Given this list of marker genes PAQR8, SPAG9, GPR21, ATP5F1A, SNX27, SLC9A9, SCRT2, TFPT, BTBD3, ITGA1, ADO, SLC38A9, SLC25A37, ERC1, APBA1, RAB2A, JAM3, RRM1, SOSTDC1, KCND2, PELO, SESN3, GRID2, ARFGEF1, TMEM245, C19orf44, KMT2D, PRSS35, STAG1, POLK, PLS3 (plastin 3), NTF3, RIMS1, GABRA3, RBMXL2, DPYSL3, RPL7, CBLN4, TMOD3, PRUNE2, BMP4, RCN3, AGA, NOX3, RASSF2, APP, RPS6KA3, BICD1, MOSPD1, SOBP, NKX2-2, PTPRK, LUC7L, GRWD1, OSBPL9, ING3, BBX (NCBI Gene Id 56987), BCKDK, FUT11, BCL11B, TLL2, CCL24, KLHL20, TSSK4, KLF5, LEF1, LGI1, EPS15, CREB5, FEN1, CRYZL1, MRPL50, JARID2, PANK3, GAS7, CBX7, MAGI1, SMCR8, ALKBH4, TBC1D22A, DAB1, NCALD, ATL3, RERE, RSKR, HSCB, CXXC5, GSX1, SAT1, RAB30, ATP5PO (NCBI Gene Id 539), ATP1B2 (ATPase Na+/K+ transporting subunit beta 2), SLC24A3, HHIP, ARID1B, NR5A2, TAF5L, TP63, PCDH7, PRICKLE2, DLG3, MSX2, KCNA1 (NCBI Gene Id 729214), MED12, HOXA5, DELE1, PIK3R1, SMARCA2 (NCBI Gene Id 95083), MBNL1, SMAD5, ZNF436-AS1, MIR17HG, TMEM150A, MVB12A (multivesicular body subunit 12A), PAX6, GHR, NRAS, CSMD3, WNT10A, KDM6A, ZNF32, OSCAR, CERT1, KCNQ4, TSHZ3, ECT2, IPO7, FEZF2, INVS, DAAM2, EDIL3, SUCO, PRPF31, RPL31, ZEB1, TOP3A, FOXP3, ACP6, TMEM104, INO80D (NCBI Gene Id 54891), ZBTB26, ZNF274, HAUS1, HOXD10, RFC1, ANGEL1, SREK1, ZNF691, TMTC2, TMEM35A, CEP97, SYNCRIP, UBE2V1, MOAP1, SH3D21, HOXA11, ASIC1, ESPL1 (extra spindle pole bodies like 1, separase), LHX1, SPEF1, ZNF521, RDH10, FOXD3, CALR3, MSL3, CBFB, DMD (dystrophin), ETV1, KLF4, CELF4, TMEM214, CRTAC1, ZBTB9, GPR119, HOXD3, ZNF189 (zinc finger protein 189), PKHD1L1, DIPK2A, ZMYM2, PTPRG (protein tyrosine phosphatase receptor type G), ARRDC3, TNFSF4, ARHGEF11, BAHD1, MXD4 (NCBI Gene Id 10608), ENSG00000291228, GABRA1, HOXB6, PIAS1, TFAP2A, ZIC4, NAP1L5, ZDHHC22, ZBTB8A, STAU1, C11orf87, NIPBL, TMEM258, PSMD11, VSTM2L (NCBI Gene Id 128434), PDE6D, LIF, ISOC1, JADE2, ARHGEF38, DNMT3A, TMEM115, BDNF, ATRN, ATP5MC3, ITSN1, UTY, SLITRK5, RELN, HMBOX1, TCF4, CA11, SIAH3 (NCBI Gene Id 283514), PLXNA2, LRRC1, DHX30, SLC31A2, INTS9, CNR1 (NCBI Gene Id 91814), MSI2, ERO1B, ZNF436, ORMDL3, NR4A3, NDUFA3 (NCBI Gene Id 4696), MREG, ZDHHC14, ST6GALNAC5, SCOC, NR2F1, APH1A, FOXN3, UBXN10, SOX2, ZNF804B, LRWD1, NFXL1, SNX1 (NCBI Gene Id 6642), TCTN3, DIS3L, SOX11, BICDL1, EDA, CNTNAP2, LRCH2 (leucine rich repeats and calponin homology domain containing 2), USF1, ERBB2, ZC4H2, NAT9, HEBP1, PHF21B, CBFA2T3, here is a description of the gene set: Comprehensive identification of all functional elements encoded in the human genome is a fundamental need in biomedical research. Here, we present a comparative analysis of the human, mouse, rat and dog genomes to create a systematic catalogue of common regulatory motifs in promoters and 3' untranslated regions (3' UTRs). The promoter analysis yields 174 candidate motifs, including most previously known transcription-factor binding sites and 105 new motifs. The 3'-UTR analysis yields 106 motifs likely to be involved in post-transcriptional regulation. Nearly one-half are associated with microRNAs (miRNAs), leading to the discovery of many new miRNA genes and their likely target genes. Our results suggest that previous estimates of the number of human miRNA genes were low, and that miRNAs regulate at least 20% of human genes. The overall results provide a systematic view of gene regulation in the human, which will be refined as additional mammalian genomes become available. Genes having at least one occurrence of the highly conserved motif M129 RRAGTTGT in the regions spanning 4 kb centered on their transcription starting sites. The motif does not match any known transcription factor binding site. species: Homo sapiens Human Gene Set: RRAGTTGT_UNKNOWN from publication Xie X, Lu J, Kulbokas EJ, Golub TR, Mootha V, Lindblad-Toh K, Lander ES, Kellis M (PMID 15735639)